The following is a description of a gene set: Any process that modulates the rate, frequency, or extent of the series of events that restore integrity to a damaged tissue, following an injury. Human Gene Set: GOBP_REGULATION_OF_WOUND_HEALING studied in species Homo sapiens, and this is the list of marker genes: PLAU, F3 (NCBI Gene Id 99486), MYOZ1, KLKB1, SH2B3, ANXA2, HMGB1, SMOC2, CLDN3, PTEN, PDGFA (platelet derived growth factor subunit A), WFDC1, TMEM97, INSL3, SERPINE1, DUOX1, REG3A, FIGNL2, CASK, ITGB1, GP1BA, REG3G, KRT1, PF4, F2, EPPK1, MIR200B, APOH, ARFGEF1, PRKCE, MIR1298, UBASH3B, KNG1, F11 (coagulation factor XI), CD36, EDN1, ALOX12, SRSF6, TMX1, NOS3, PTK2, WNT4, KANK1, HRG, F2R, TNFAIP3, NFE2L2, VTN, ANXA1, F12, TNF, FOXA2, SERPINE2, OCLN, EMILIN2, FERMT2, DDR2, FERMT1, PLAUR, MMRN1, VIL1, TFPI, FGF2, ENPP4, PLG, PRKG1, CADM4, CD9, SERPING1, EPHB2, PROS1, PHLDB2, F2RL1, MIR15B, SERPINF2, CEACAM1 (CEA cell adhesion molecule 1), HBEGF, HTN3, CD109, ST3GAL4, ANO6, CLDN1, EMILIN1, ADTRP, PROC, CLASP2, SMAD3, SERPINB2, PRDX2, FGA, MIR34A, MIR29A, C1QTNF1, ALOX5, DUOX2 (NCBI Gene Id 82430), MIR221, FGG, TNFRSF12A, CPB2, RREB1, XBP1, FGB, MTOR, MYLK, F7, PDGFB, ADAMTS18, MIR451A, ADRA2A, TBXA2R, FAP (NCBI Gene Id 2191), THBS1, APOE, AJAP1, VEGFB, CLEC7A, DMTN, THBD, CAV1, CLDN4, HPSE, FOXC2, TSPAN8, CCN4, TAFA5, ACTG1, PDGFRA, CLASP1, APCS, SERPINC1, HTN1, CRK, SLC12A2, PLAT, HRAS (HRas proto-oncogene, GTPase), USF1, PRKCD